Given this list of marker genes Ctcf, Msl2, Pcbp2, Ruvbl2, Ahdc1, here is a description of the gene set: Bridging together two regions of a DNA molecule. Mouse Gene Set: GOMF_DNA_DNA_TETHERING_ACTIVITY studied in species Mus musculus